The following is a description of a gene set: from publication Chen WV, Delrow J, Corrin PD, Frazier JP, Soriano P (PMID 14981515) species: Mus musculus Mouse Gene Set: CHEN_PDGF_TARGETS Up-regulated PDGF targets identified by a gene-trap screen. We developed a versatile, high-throughput genetic screening strategy by coupling gene mutagenesis and expression profiling technologies. Using a retroviral gene-trap vector optimized for efficient mutagenesis and cloning, we randomly disrupted genes in mouse embryonic stem (ES) cells and amplified them to construct a cDNA microarray. With this gene-trap array, we show that transcriptional target genes of platelet-derived growth factor (PDGF) can be efficiently and reliably identified in physiologically relevant cells and are immediately accessible to genetic studies to determine their in vivo roles and relative contributions to PDGF-regulated developmental processes. The same platform can be used to search for genes of specific biological relevance in a broad array of experimental settings, providing a fast track from gene identification to functional validation., and this is the list of marker genes: Arid5b, Plekha1, Uck2, Tiparp, Jade1, Slc2a2, Epha2, Sgpl1, Got1, Gpd2 (glycerol phosphate dehydrogenase 2, mitochondrial), Schip1, Zfand5, Klf9, Mcl1, Klf2, Csrnp1, Myo1e, Lmna